The following is a description of a gene set: TP53 Regulates Metabolic Genes Mouse Gene Set: REACTOME_TP53_REGULATES_METABOLIC_GENES species: Mus musculus, and this is the list of marker genes: Prdx1, Prkaa1, Lamtor1, Sfn, Ddit4, Tigar, mt-Co2, Cox6b1, Gpi1, Mlst8, Cox4i2, Gpx2, Rraga, Cox6c, Rragd, Mtor, Gsr, Akt1, Cox5a, Akt3, Ndufa4, mt-Co1, Higd1c, Prdx2, Prkag2, G6pdx, Cox7c, Ywhaq, Txn1, Cox4i1, Rragc, Cox7a1, Cox7a2, Prkab2, Lamtor4, Gm10053, Cox7a2l, Cox5b, Cox8a, Prkab1, mt-Co3, Ywhaz, Lamtor5, Gls2, Tsc2, Txnrd1, Rptor, Sesn3, Ywhah, Tsc1, Rheb, Cox8c, Cox6a2, Akt2, Rragb, Sesn2, Ywhag, Cox6a1, Ywhae, Sesn1, Gls, Prkag3, Prkag1, Lamtor2, Ywhab, Cycs, Prdx5, Lamtor3, Cox6b2, Cox7b, Slc38a9, Prkaa2